Given this list of marker genes Ago4, Bhlhe40, Fam181b, H2bc21, Phex, Ptger2, Hsf2, Ppp1r13b, Tshz1, Gm4894, Hnrnpu, Tcte1, Zfp474, Ugdh, Vrk1 (NCBI Gene Id 22367), Hoxc8, Psd3, Gys2, Sh3gl2, Tmx4, Brdt, Rftn2, Afdn, Doc2a, Col2a1, Cdk5rap2, Dok2, Ywhag (tyrosine 3-monooxygenase/tryptophan 5-monooxygenase activation protein, gamma polypeptide), Myef2, Slc39a12 (NCBI Gene Id 99291), Syt4, Sat1, Il11, Helz, Ppp1r14bl, Spout1, Siah1a, Rab9b, Siah1b, Cdc42ep3, Ssbp2, Elavl1, Saysd1, Pgm2l1, Myt1l (myelin transcription factor 1-like), Gpr12, Btbd10, Usp45, Polr3b, Yeats2, here is a description of the gene set: Mouse Gene Set: MIR_1191B_3P from publication Chen Y, Wang X (PMID 31504780) Genes predicted to be targets of miRBase v22 microRNA mmu_miR_1191b_3p in miRDB v6.0 with MirTarget v4 prediction scores > 80 (high confidence targets). species: Mus musculus